Given this list of marker genes RPL9, LAMA2, ACTN2, CRPPA, KANSL1, GYG1, MTRFR, LMOD3, CHRND, SPAST, USP8, TSEN15 (tRNA splicing endonuclease subunit 15), VHL, CAPN1, PLEC, BVES, SORD, PTPN11 (NCBI Gene Id 84990), FBXO28, SLC39A14, PDXK, GBF1, GMPPB, PRPS1, KCNJ10, SGCB, SLC25A4, SLC25A21, VWA1, HOXA13, TARDBP, ATXN2, MB, WASHC5, COL25A1, DDHD2, IGHMBP2, CEP126, MYH2, OPTN (optineurin), DUX4L1, PODXL, DNAJC6, FLNC, SEPSECS, RPS17, RPL27, HACE1, PDGFB, GLE1, DYNC1H1, WARS2, PTRHD1 (peptidyl-tRNA hydrolase domain containing 1), CHMP2B, ERCC1, TSEN54, DGUOK, WDR48, PPARG, SLC52A3, YARS1, BRAT1, MYMK, SPG21, CACNA1B, CACNA1G, SNAP25, RRM1 (ribonucleotide reductase catalytic subunit M1), SLC33A1, MAP3K20, CHRNE, FBN2, TDP1, AP5Z1, STIM1, RAF1, CHAT, COL13A1, RNF170, SIGMAR1, CAPN3, PLAA, MAPT, LMX1B, SCN8A, GBA2, SRPX2, PACS2, FA2H (fatty acid 2-hydroxylase), SPTLC1, AMPD3, MTTP, GCH1, VPS37A, PI4K2A, NF2, L1CAM, SECISBP2, ACTL6B, PLXND1, DAO, VAMP1, PCCB, EMD (NCBI Gene Id 2010), CLTC, ATP1A3, MYOT, ALDH18A1, RPS20, DHX16, SRY, NF1, IBA57, SYNGAP1, KARS1, HNRNPDL, ESAM, GALC, SDHB, CYP27A1, PYROXD1, MORC2, DPH5, GRIN2D, RPS29, TRPV4, PHYH, VMA21, KATNB1, JAG1, DDC, FBN1, FGFR2, KCNA2, SYT2, ELOVL4, ATL1, ALX3, GFPT1, SCN3A, FKTN, MYBPC1, SLC25A1, RTN2, CNKSR2, ATP1A1, RPL11, ANO10, PI4KA, BAP1, SLC5A6, ERBB4, B4GALNT1, PUS1, OSTM1, DNM1, GDAP2, KLHL9, ITPR1, SYNJ1, PTS, PABPN1, DALRD3, PRORP, HK1, ATP7B, FLNB, REV3L, BICD2, SEPTIN9, MYO9A, EMC1, GRM7, C19orf12, CFL2, CPT1C, MUSK, WARS1, CYP7B1, SLC52A2, TYMP, ATP1A2, FBXW11, POMGNT1, NGLY1, MYL2, LRP4, LRSAM1, GNB4, ADAR, UNC13A, FBLN5, FILIP1, SPART, ATP6V1A (NCBI Gene Id 523), AP3B2, MED11, COG4, PRDM13, ALX1, TSEN2, TBK1, HACD1, RBM8A, KIF1A, RNU7-1, FUS, ORAI1 (ORAI calcium release-activated calcium modulator 1), HADHA, SLC39A13, DOCK6, PDK3, ASH1L, COLQ, SMN1, TBCE, GDAP1, DYRK1A, LDB3, HSPB8, TRPS1, PMP2 (NCBI Gene Id 5375), AFG3L2, LBR, SCO2, NEB, TRIM2 (NCBI Gene Id 23321), GABBR2, TBX5, UNC45B, GABRB2, TRAPPC11, IFIH1 (interferon induced with helicase C domain 1), ARV1, PIK3CA, TK2, SQSTM1, GNE, CADM3, LIMS2, CUL7, EIF2B2, KDM5C, NDRG1, MTHFR, FGD4, PHKA1, RPS10, GDF11, RPL15, ASXL2, PRX, PYCR2, EMILIN1, KIFBP, EBF3, RPS7, ZFYVE26, EGR2, SMARCE1, NTRK2, ATP5MC3, WWOX, VPS13D, FOXG1, TRIM32, MYMX, PEX7, DNAJB6, ABCD1, DCTN1, MPZ, TWNK, UBA5, GFAP, SACS, PLOD1, DHTKD1, SCN1A, FBXO38, CSGALNACT1, FRMD4A, SLC25A19, CHRNB1, SPEG, SCN4A, NDUFA9, ERGIC1, TIMM8A, ADA2, MTAP (methylthioadenosine phosphorylase), HYCC1, BAG3, SZT2, LIPE, H4C5, PHKB (phosphorylase kinase regulatory subunit beta), RPS15A, KIF5A, LTBP4, POLG2, FIG4, CAMSAP1, MT-CO1, FLNA, VPS13A, HMGCR, SPG7, BTD, GMPPA, NDUFC2, KCNB1, RAB7A, KDM1A (NCBI Gene Id 23028), DKK1, BIN1, AKT1, SMCHD1, CCDC8, ATP6V0A2, ALS2, EXTL3, PPARGC1A, POMT1, MYF6, RPL18, COX6A1, LAMB2, MTPAP, MTRR, HEATR3, MEGF10, KCNC2, RRM2B, SPR, BRF1, DNA2, FGF12 (fibroblast growth factor 12), KIDINS220, BSCL2, AAAS, DMXL2, TRAF7, GABRA3, DDHD1, SOD1, EIF2B3, NCAPD3, CACNA2D1, COL6A1, MARS1, RPL35, HEXB, FZR1, AIFM1, COL6A2, ACOX1, PRNP, ALG2, DHPS, LRP12, RFXAP (NCBI Gene Id 5994), FARS2, SMO, CYFIP2, HMBS, PAX3, MRPS2, HSPB3, TRIP4, MYH14, KLHL41, PAX1, UBAP2L, CIDEC, EBP, ANXA11, MTMR14, CCNF, DYM, CCND1, HINT1, POMT2, ERCC8, DUX4, AR, CAV3, RPL5, RYR1, CDC42BPB, RYR3, GAN, RPS24, NIPA1, ACTB, PON3, SBF2, TNPO3, CACNA1A, POPDC3, PSAP (NCBI Gene Id 83009), BRAF, POLR3A, GNB1, PRPH, UFC1, ERCC6, KCNA1, INF2, RPL8, HNRNPA2B1, PARS2, PON2, GARS1, PON1 (paraoxonase 1), RILPL1, FLI1, SLC35C1, FHL1, PPOX, GABRG2, TRAK1, AK9, EPHB4, CLP1, ITPR3, PNKP, GPHN, MYPN (NCBI Gene Id 84665), MT-ATP6, MME, SCYL2, RPS19, ALG11, DNMT3B, CPLANE1, LRIF1, LPIN1, SMN2, SPTLC2, TPM3, ACTA1, TAF15, LMNA, TCAP, SLC6A3, DOK7, CHRNA1, SLC1A2, FKRP, NEFL, UBTF, POU3F4, FMR1, DYSF, SPRED2, FRG1, RNASEH1, RPS28, AMPD1, RETREG1, ERLIN2, TMEM43, POGLUT1, GJB1, POMGNT2, TREM2, PFN1, POMK, GATA1, NECAP1, GLT8D1, ASAH1, RPS27, MAP3K7, SCYL1, SDHD, POLG, UBAP1, ANO5, MCM3AP, SVBP, NUS1, RPL35A (NCBI Gene Id 6165), SMPX, SLC5A7, TNR, DNAJC12, SDHAF1, MLIP, PIGA, SYNE2 (NCBI Gene Id 26075), SLC12A6, CELF2, OPA1, PIGN, MINPP1, NAA60, HCN1, PLOD3, NUP62, DPAGT1, SNUPN, ATL3, AFG2A, DNM1L (NCBI Gene Id 692222), PNPLA6, ADSS1, KCNJ2, CLCN1, TGFB3, ARSI, DNM2 (NCBI Gene Id 338330), GRIK2, IDUA, SPG11, LARGE1, DNAJB2, CRYAB, FDX2, EEF1A2, SBF1, AP4M1, HARS1, DARS2, MT-CO3, ABHD5, SGCA, TARS2, EYA1, PRR12, DES, NEFH, GAA, PNPT1, TIA1, FXN, SDHA, CFAP410, GFM2, LIG3, SLC16A2, PCCA, TRIO, KAT6A, NOTCH2NLC, MPV17, RASA1, CDK19, ATRX, PMP22, TSEN34, AARS1, DHDDS, SH3TC2, PLIN4, DAG1, RAD51C, DMD, UBQLN2, CACNA1S, DPM3 (NCBI Gene Id 54344), ASXL1, CNBP, PNPLA2, MYH7, NEK1, RHOBTB2, KCNJ18, TERT, CLDN11, GNB2, VCP, RPL26, HADHB, PPP3CA, SPTAN1, UFSP2, TSR2, CPOX, TTN, COQ7, NUP54, PIGP, SGCD, CHCHD10, SGCG, MFN2, COMP, SLC13A5, SLC30A9, RPS26, GABRA2, REEP1, OBSCN, HSPG2, SYNE1, SUFU, LYST, COA7, ADAMTS15, ITGA7, MICU1, HSPD1, TFG, HNRNPA1, SMG9, SARDH, ANG, RNF31, ADCY5, SELENON, YWHAG, RAI1, SLC31A1, PIEZO2, RPL31, DSTYK, ALAD, MATR3, VAPB, TNNT1, PLP1, COL12A1, LGI4, PLIN1, ADGRG1, ASNS, SMARCB1, KPNA3, KBTBD13, CD59, LAMP2, COX20 (cytochrome c oxidase assembly factor COX20), RARS1 (NCBI Gene Id 84715), ALG14, SLC38A3, GABRA5, TPM2, RAPSN, JAG2, OBSL1, HSPB1, SALL4, TBX3, MT-TE, GIPC1 (NCBI Gene Id 10755), KIF1B, KY, ATP13A2, FGF13, EIF4A3, COL6A3, CAV1, AGRN, SLC18A3, TBCK, here is a description of the gene set: species: Homo sapiens Human Gene Set: HP_ABNORMALITY_OF_THE_MUSCULATURE_OF_THE_LIMBS Abnormality of the musculature of the limbs